Given this list of marker genes KCNMB2, DNAJB9, PDAP1, KCNJ2, MIR19A, FAM114A2 (NCBI Gene Id 55912), ECEL1, CHGB, ME1, MMP20, NCDN, HLF, RNF185, COL6A1, USP26, LRRC18, GPIHBP1, ZBTB44, GET3, ATP10B, RIC3, SLC6A16 (NCBI Gene Id 95514), HES7, SHISAL2A, PCDH12, KCNK2, FAM168B, NBEA, ZNF394, PRRX2, NIPAL2, PLCD3, SLC23A2, ST18, DDX52 (NCBI Gene Id 113523), CWC25, GCN1, PHOX2B, IMP4, ADRA2A (adrenoceptor alpha 2A), TRIM42, MIR185, TERB1, PIM2, MIR676, ABO, MPP1, PSKH1, OBSCN, CNGA4, TRAPPC3, FOXE3, FGF23, MIRLET7B, MORC4, ZBTB46, SPACA3, HCK, SH3BP5, LRRC7, HECW1, COL1A2, LRRK2, FAM83E, GARIN5A, NIPAL4, TMEFF2, PLD1, SP2, CHRDL1, GPATCH3, LCAT, THBS1, GEMIN5, IFNA4, ALLC, EFCAB10, CPA1, SMPD3, TMTC2, CLDN19, C9orf78, TFIP11, SUCNR1 (succinate receptor 1), SFTPA1, UBE2J2, EHMT1, MARCHF11, STARD13, PLD2, EIF2B5, COX8BP, HOXD11, GSX2, CCDC146, GFI1B, ACOD1, PLCXD2, ZSWIM4, SLC35E1, FAM53C, CTCFL, TTC12, GLRB, TRAK1, CRACR2B, CMBL, MS4A7, HSPG2, CAGE1, DAB1, KCNV1, NOXO1, ELN, CST11 (cystatin 11), PPFIA2, NKX3-2, RNF115, CRYGS, SDK1, TCAF2, TMEM174, GARIN4, TRAM2, BEGAIN, PDLIM2, GOPC, HTR3B, NTN1, MAGI2 (membrane associated guanylate kinase, WW and PDZ domain containing 2), NDRG3, PRKG2, TAFA3, ATP6V1D, NIP7, DDR1, IL23R (NCBI Gene Id 94006), CCDC148, SYN2, MIR412, here is a description of the gene set: Myeloid dendritic cells (DC) and macrophages play an important role in pathogen sensing and antimicrobial defense. Recently we demonstrated that infection of human DC with intracellular bacterium Listeria monocytogenes (L.monocytogenes) leads to the induction of the immunoinhibitory enzyme indoleamine 2,3-dioxygenase (Popov et al., J Clin Invest, 2006), while in the previous studies L.monocytogenes infection was associated with a rather stimulatory DC phenotype. To clarify this discrepancy we performed comparative microarray analysis of immature mo-DC (immDC), mature stimulatory mo-DC (matDC) and mature inhibitory DC either stimulated with prostaglandin E2 (PGE2-DC) or infected with L.monocytogenes (infDC). Studying infection of human myeloid DC with Listeria monocytogenes, we found out, that infected DC are modified by the pathogen to express multiple inhibitory molecules, including indoleamine 2,3-dioxygenase (IDO), cyclooxygenase-2, interleukin 10 and CD25, which acts on DC as IL-2 scavenger. All these inhibitory molecules, expressed on regulatory DC (DCreg), are strictly TNF-dependent and are in concert suppressing T-cell responses. Moreover, only DCreg can efficiently control the number of intracellular listeria, mostly by IDO-mediated mechanisms and by other factors, remaining to be identified. Analyzing publicly acessible data of transcriptional changes in DC and macrophages, infected by various pathogens and parasites (GEO, GSE360), we noticed that infection of these cells with Mycobacterium tuberculosis causes transcriptional response, comparable with the one caused by listeria in human DC. In fact, granuloma in tuberculosis and listeriosis in vivo are enriched for myeloid DC and macrophages characterized by regulatory phenotype. In summary, regulatory myeloid DC and macrophages may play a dual role during life-threatening granulomatous infections, such as tuberculosis: on one hand, regulatory myeloid cells promote pathogen containment by efficiently killing intracellular bacteria, on the other hand these cells inhibit granuloma-associated T cells and thereby might be involved in the retention of TNF-controlled granuloma integrity protecting the host from granuloma break-down and pathogen dissemination. species: Homo sapiens Genes up-regulated in dendritic cells: immature versus mature inhibitory infected with L. monocytogenes. from publication Popov A, Driesen J, Abdullah Z, Wickenhauser C, Beyer M, Debey-Pascher S, Saric T, Kummer S, Takikawa O, Domann E, Chakraborty T, Krönke M, Utermöhlen O, Schultze JL (PMID 18802101) Human Gene Set: GSE9946_IMMATURE_VS_LISTERIA_INF_MATURE_DC_UP